The following is a description of a gene set: Any process that stops, prevents, or reduces the frequency, rate or extent of cardiac muscle growth. Mouse Gene Set: GOBP_NEGATIVE_REGULATION_OF_CARDIAC_MUSCLE_TISSUE_GROWTH species: Mus musculus, and this is the list of marker genes: Pak1, Rbm10, Sav1, Apc, Cited2, Hdac2 (NCBI Gene Id 28131), Trp73, Gja1, Kcnk2, Nog, Mir1a-2, Ppara, Gsk3a, Tomm70a, Pi16, Yy1, Ctdp1 (NCBI Gene Id 67655), Pten, Rgs2, Cav3, Vgll4, Cxadr, Zfp418, Jarid2, G6pdx, Rgs4, Rbp4, Mapk11, G6pd2, Tbx5, Foxp1 (NCBI Gene Id 73231), Tgfbr2